The following is a description of a gene set: Binding to double-stranded methylated DNA. Methylation of cytosine or adenine in DNA is an important mechanism for establishing stable heritable epigenetic marks. studied in species Mus musculus Mouse Gene Set: GOMF_DOUBLE_STRANDED_METHYLATED_DNA_BINDING, and this is the list of marker genes: Wt1, Zfp445, Mbd1, Macroh2a1, Zfp57, Mecp2, Egr1